The following is a description of a gene set: An abnormality of the iris, which is the pigmented muscular tissue between the cornea and the lens, that is perforated by an opening called the pupil. species: Homo sapiens Abnormality iris morphology Human Gene Set: HP_ABNORMALITY_IRIS_MORPHOLOGY, and this is the list of marker genes: IMPG2, BDNF, RERE, TRIP13, PEX3, WDR45, OCRL, WNT10B, COL3A1, IMPG1, TCTN1, FANCD2, POMGNT2, HHAT, MC1R, LTBP2, ALG2, SPRED2, MT-TS2, NDN, CPAMD8, ATP10A, ROBO1, TRIM44, RRAS2, PRKCZ, ZEB2, MKS1, RIT1, BEST1, HLA-B, MFAP5, FLNA, SLX4, POLR1D, FANCB, SALL4, CLIP2, FLI1, BMP4, GABRD (NCBI Gene Id 2563), ACTA2, MYO7A, ARL6IP6, PDE4D, POLR1B, TBL2, PCYT1A, POMK, KIT, PDPN, ELP1, SNRPN, VSX1, GMPPB, TMEM218, VPS13B, USH2A, HPS6, EPS15L1, SLC25A11, TMEM67, TBX4, XYLT2, LAMB2, MYOC (NCBI Gene Id 4653), KRAS, SH3TC2, PAX3, GTF2IRD2, FANCA, MTSS2, TCEAL1 (transcription elongation factor A like 1), SOS2, ADAMTSL4, KCTD1, FANCI, VWA8, COL8A2, LZTR1, GMPPA, TGFBR1, CPLX1, BTRC, ATOH7, SRD5A3, NDP, PTPN11, LIG4, PTCH1, DIS3L2, NSUN2, NELFA, ATP6V1A, LMX1B, NDUFB11, TUBA1A, PEX1, TGIF1 (NCBI Gene Id 91941), FANCL, MAFB, MMP23B, FOXE3, CEP290, MDH2, C12orf57, PEX11B, PEX26, CTBP1, COX7B, MIR184, CRYBA4, SALL1, MED12L, EDC3, POLR1C, COL4A1, RFWD3, TCTN3, MAT2A, PTEN, NF2, LPAR6 (NCBI Gene Id 10161), TGFBR2, ITPR1, SALL2, TONSL, SUFU, SLC45A2, KIF21A, LETM1, DACT1, FAM111A, NOTCH2, CYSLTR2, AAAS, TMEM107 (transmembrane protein 107), LOXL1, PXDN (peroxidasin), PEX10, MAX, CEP120, TINF2, CHRDL1, INPP5E, MYO5A, FANCF, RPGRIP1L, CPLANE1, TFAP2A, NOD2, HYLS1, RASA2, GAS1, VPS37D, DYRK1A, TYRP1, PNPLA6, H19, CRYBB2, POMT1, TMEM127, COL25A1, KIAA0586, SEM1, ERCC4, SMO, GFAP, MAF, TMEM237, CRYGD, SIN3A, RBP4, TMEM231, KCNAB2, B4GAT1, RPGRIP1, C1QTNF5, IFT74, RAD51C, POGZ, CCDC22, RAD51, FKRP, B3GALNT2, FANCC, FKBP6, CRPPA, LRMDA, SMAD4, SOX2, CSPP1, GTF2I (general transcription factor IIi), PRKAR1A, CBL, PTCH2, VHL, TMEM270, FGFR2, EDN3, SKI, KRT25, LRP5, AKT1, CEP78, PEX13, SDHD, PRDM16, ZIC2, ALX3, PDZD7, ASPH, CHN1, LOX, PIGG, LRP2, OCA2, DLX5, FH, ALG3, ARSG, MRAS, TBR1, STX1A, ELP4, PITX2, KMT2D (lysine methyltransferase 2D), PHOX2A, IGBP1, SDHA, NSD2, SNAI2, FZD5, OVOL2, CDH23, MPDZ, NF1, FOXC1, KITLG, NRAS, MBTPS2, ARL13B, DLX6, PUF60, CLRN1, TBX2, TOGARAM1, SDHB (succinate dehydrogenase complex iron sulfur subunit B), UBE4B, HS2ST1, NPHP1, RB1, DTNBP1, SOX10, SPRED1, NOTCH3, STIM1, THSD4 (NCBI Gene Id 79875), ARMC9, CEP104, SLC24A5, XRCC2, ESAM, ABCB6, SPTBN1 (NCBI Gene Id 91654), PCDH15, LIMK1, MLPH, POU6F2, HSPG2, LARGE1, SHH, IGF1R, PIK3R1 (phosphoinositide-3-kinase regulatory subunit 1), LDHD, FGFRL1, PEX14, EDNRB, MPZ, TGFB3, DLL1, HCCS, SF3B1, ADAMTS17, BAZ1B, NODAL (NCBI Gene Id 8114), GDF3, DPYSL5, TRPM3, HPS1, RLIM, EIF4H, RRAS, TUBB2B, TRIM28, TMEM216, B3GLCT, TRIM37, FANCE, DLST, WT1, CYP1B1, KRT71, PEX16, SMCHD1, BAP1, TBX22, VPS35L, PIBF1, RAF1, PRR12, FBXW4, PEX5, COQ2, HPS5, ZEB1, SIX6 (SIX homeobox 6), TUBB3, AP3D1, MSH6, DAG1, TEK, MLXIPL, FKTN, RSPO2, PEX19, HRAS, ACTG1, NAA10, KANSL1, ESPN, BRIP1, WASHC5, USH1G, HMX1, LIPH, MAB21L2, SEMA3E, GJA8, TGFB2, PAX6, UBE2T, CASZ1, BLOC1S6, AP3B1, KIF1B, GNAQ, ACTB (NCBI Gene Id 60), CHD7, MAPK1, SDHC, SOS1, FGF3, BRCA2, UBE3A, TENM3, USH1C, SPEN, METTL27, PAH, CRYAA, KIFBP, POMGNT1, KIAA0753, RAP1B, ELN, SMAD3, RXYLT1, HMGB3, MIR204, GTF2IRD1, DHCR7, MMP2, DNAJC30, CRYGC (NCBI Gene Id 1420), HPS4, FOXH1, MAGEL2, TCTN2, CC2D2A, AHI1, MMP14, NCF1, REST, EPG5, PALB2 (NCBI Gene Id 79728), ERCC6, FGFR1, CRYBB1, WDR73, HEY2, SIX3, PRPH2, ARL3 (ADP ribosylation factor like GTPase 3), GNA11, B9D1, SMAD2, BLOC1S3, GRHL2, KRT74, PEX12, POMT2, RAB27A, YAP1 (NCBI Gene Id 10413), PEX2, TCOF1, HARS1, FANCM, FBN1, GZF1, PEX6, CRIPTO, ZNF423, PHOX2B, KATNIP, BLOC1S5, GPC3, WHRN, MYH11, CBY1, BUD23, CENPF, TP63, COL18A1, RET, ERF, CDON, LUZP1, MAD2L2, DCT (NCBI Gene Id 1638), PORCN, BCOR, VSX2, BRCA1, RHOA, RFC2, FANCG, WNT3, PMP22, TMEM138, TXNDC15, DISP1, EFEMP1, CIB2, GJA1 (gap junction protein alpha 1), PDE6D, TYR, MITF, DDX6, ROR1, ADAMTSL1, OFD1, GLI2, ADNP, ANK1, LYST, FZD4, NR4A2, PRKG1 (protein kinase cGMP-dependent 1), ADGRV1, CEP41, SDHAF2, MYLK, GPR143, HERC2, FGF8, B9D2